Given this list of marker genes Ncoa2, Ncor2, Tbl1xr1, Tgs1, Tbl1x, Smarcd3, Med1, Chd9, Sin3a, Hdac3, Helz2, Carm1, Ncoa1, Sin3b (transcriptional regulator, SIN3B (yeast)), Fabp1, Rxra, Ppara, here is a description of the gene set: studied in species Mus musculus Mouse Gene Set: REACTOME_REGULATION_OF_LIPID_METABOLISM_BY_PPARALPHA Regulation of lipid metabolism by PPARalpha